Given this list of marker genes TRIM33, LAYN, TRIM8, SYNC, LRTOMT, UNC93B1, ETV3, IL18, PBXIP1, PLEKHA8P1, PRMT3, LZTS2, PDGFD, ATL3, ZRANB1, CMAS, NIPAL3, PLEKHN1, FAM53B, CDC14A, RUNX3, ARFGAP2, CD53, PDZD7, ARHGAP20, POLD4, CACNA1E, TUT1, CD5 (NCBI Gene Id 921), LAG3, RAB39A, NUMA1, FGF23, ELOVL1, SELP, CD247, AKT3, GPD1 (NCBI Gene Id 2819), PRDX6, DCLRE1C, VWA1, LTBR, NLRP3, ST7L, POLR2L (RNA polymerase II, I and III subunit L), RSF1, PI4KB, NT5C2, TAF5, CTTNBP2NL, DMBT1, FERMT3, PUM1, MMRN2 (multimerin 2), CCN1, MARK1, PATL1, JAML, SLAMF9, GOLPH3L, RELT, HHEX, SBF2 (SET binding factor 2), FUCA1, C2CD2L, NCAM1, XCL1, PTPN6, RNASEL, IRAG2, MICAL2 (NCBI Gene Id 9645), PGM2L1, DDX23, MAPKAPK2, RAB3GAP2, CD3E, GDPD5, PRPF38B, TXNDC12, SV2A, LCOR, CTSS, SLC2A3, EPC1, CPNE8, CFAP68, PTPRC, SLF2, CAPZA1, SIK3, EPHA2, KAZALD1, ZNF365, HIPK1, NCF2, GRIN2B, CADM1, YRDC, BCL2L14, MARVELD1, VDAC2, TSPAN4, FUT11, SRRM1, CELF1, ARHGDIB, MR1, ELK4 (ETS transcription factor ELK4), ZNF384, DPP3, SLC43A1, PUS7L, C1orf122, BATF2, FCRL1, CD84, CTSW, GTF2H1, IVL, GPA33, SLC35C1, FLI1, CTBP2, GFI1 (growth factor independent 1 transcriptional repressor), SPATA6, TCIRG1, RAB1B, SLC30A7 (NCBI Gene Id 148867), BUD13, CDKN2C, ARHGAP30, FCRL5, PSD, ZNF202 (zinc finger protein 202), PICALM, SIPA1, BDNF, PDZRN4, MARK2, CALHM2 (calcium homeostasis modulator family member 2), AAMDC, ARAP1, HPS5, ELOA, SYTL1, WDFY4, CD69, FCGR3A, MACO1 (macoilin 1), RPS3 (NCBI Gene Id 6188), DGKZ, C12orf57, MMP1, LPXN, FCGR3B, SPRR4, EXTL2, SLC41A1, MINDY1, ARF3, ITPR2, DUSP5, SEC24C, SORL1, SNCG, PRKACB, SF1, MLLT11, INPPL1, TNFAIP8L2, RTN3, GPR137B, IL18BP, GNL2, NIBAN1, NKAIN1, VCAM1, KDF1, TIAL1 (TIA1 cytotoxic granule associated RNA binding protein like 1), PDIK1L, ESRRA, TMEM69, SPI1 (Spi-1 proto-oncogene), TBC1D10C, LIN28A (lin-28 homolog A), BTBD16 (BTB domain containing 16), RPS6KA4, NRP1, ZNF687, ANKRD1, ACSL5, COP1, GRK2, CAP1, MAP4K2, LCK, BLNK, PLCB3, IL2RA, ELAVL4, PAX6, CAMK1D, SLC26A9, ZCCHC24, VPS11, CRTC2 (CREB regulated transcription coactivator 2), ADAMTS4, LALBA, CDC42SE1, CREBL2, PRUNE1, TNNI2, ST3GAL4, ATP13A2, XCL2, ANK3, TXNIP, KCNAB2, TMEM258, PACC1, XPNPEP1, GAB2, FEN1, PRF1, LAMC1, TYSND1, GAL3ST3, MMP7, NDUFS2, DENND2D, RIN1, RXFP4, SSBP3, CBL, EHF, RAB30, CCDC88B, KCNQ1, NRGN, SELL, WASF2, STX5, PLEKHS1, GPN2, RHOG, C11orf24, KIAA0040, BIN2, GATA3, APOLD1, ZDHHC5, ITPKB, MSANTD2, ABLIM1, POU2AF1, LRFN4, APH1A, IPO7, FFAR4, IRAK4, OMA1, PAFAH2, MFN2, here is a description of the gene set: Human Gene Set: PEA3_Q6 Genes having at least one occurrence of the motif ACWTCCK in the regions spanning 4 kb centered on their transcription starting sites. This matches the ETV4 transcription factor binding site V$PEA3_Q6 (v7.4 TRANSFAC). species: Homo sapiens